Given this list of marker genes PRLHR, GPR173, NSA2, MFN1, PAK1, MIS18A, LAMA4, BOD1L1, MAGI3, C1orf116, BTF3L4, CSMD1, DDX6, NR2F2, SOS1, IFNAR2, RSBN1, ANKRD18A, HCN1, ELAPOR2, GXYLT1, HMGCR, VGLL4, INO80D, TNRC6B (trinucleotide repeat containing adaptor 6B), UGP2, PTCH1, ELL2, RAB39B, GCLC, KAT2B, ARHGEF33, NOD1, RPA1, CCDC28A, GABPB1, TAOK1, KCNB1, CREB1, CAMSAP1, CHL1, OPHN1, ATG4C, COL15A1, CHST7, DDC, SNX27, DHRS1, TCF7L2, ATG4B, ZBTB20, DLX2, THSD7A, IKZF5, SYTL5, CCER1, FAM168A, ACTG1, ERRFI1, GIGYF2, RTN3, SH3BGRL, PIERCE2, ZNF521, TBL1XR1, NUDT15, DCAF1, SEC22C, VAMP3, SPTLC2, GTF2A2, ESCO1, OR12D3, ZNF816, PLPBP, RMDN1 (NCBI Gene Id 51115), NAV1 (NCBI Gene Id 89796), FBXO32, MBNL3, OSBPL6, KIF14, YAP1, UBE2F, ZNF146, ZNF99, CLDN16, PRMT6, CPD, C17orf107, CAVIN2, DGKH, BLCAP, PURA, MYLK3 (NCBI Gene Id 91807), USP12, BTG2, PRKAG2, GALNT1, SMIM12, HIPK2, ZNF160, ZNF765, MAGEA12, NAP1L1, CCDC144NL, ENC1, PGLYRP4, TULP4, PPP2R3A, TECTB, TM9SF2, BHLHE40, NFYA, TMEM135, ASB1, CCSER1, C1orf21, RAPGEFL1, PXN, KDM4C, ZFAND5, KPNA6, ZNF605, MSX2, TRAPPC13 (NCBI Gene Id 80006), ADAM28, DUSP16, ZNF629, CDKN2AIP, TRIOBP (NCBI Gene Id 23712), PA2G4, WDR33, NT5E, FUT9, DNAJC5G, GJA9, PCLO, RNF149, CLSTN2, GRM8, FER1L6, ZNF721, MYBPC1, ZNF705A, YAE1, RPRD1A, NSD1, ETNK1, SPTY2D1, FSIP1, MAGEB6, LARS1, TRPM7, RNF141, ZDHHC21, VDAC3, MYPOP, XKR4, CPM, POU4F2, EXD1, SNCA, ZNF410, SRGAP2, RBM15, PSMD1, VPS72, TBC1D23, SLC2A2, SBSPON, KIAA1210, SLC25A22, GRIP1, PRELID2, BRAP, DSTYK, NAP1L5, ARL6IP1, EYA1, CUL5, ZNF705D, DDT, PHF20L1, THEMIS, TMEM35A, GFOD2, HECW2, C15orf48, CCNT2, GCSAML, HOOK1, XDH, MTF2, JUND, MSI2, ZBTB43, ZNF37A, EOGT, CLSPN, SRSF1, ZNF138, UBN1, LDHAL6B, TMEM260 (transmembrane protein 260), GPR107, FBXO8, RNASEH2B, CHCHD3, HERPUD1, PRDX6, ZNF584, USP46, PDGFRA (platelet derived growth factor receptor alpha, NCBI Gene Id 5156), OTX1, TMEM167B, DDX46, SPTSSB, ARFGAP1, TM9SF3, here is a description of the gene set: Genes predicted to be targets of miRBase v22 microRNA hsa-miR-6515-3p in miRDB v6.0 with MirTarget v4 prediction scores > 80 (high confidence targets). Human Gene Set: MIR6515_3P from publication Chen Y, Wang X (PMID 31504780) studied in species Homo sapiens